The following is a description of a gene set: The change in morphology and behavior of a mast cell resulting from exposure to a cytokine, chemokine, soluble factor, or to (at least in mammals) an antigen which the mast cell has specifically bound via IgE bound to Fc-epsilonRI receptors, leading to the initiation or perpetuation of an immune response. Mouse Gene Set: GOBP_MAST_CELL_ACTIVATION_INVOLVED_IN_IMMUNE_RESPONSE species: Mus musculus, and this is the list of marker genes: Grp, Hmox1, Gata2, Ighe, Lyn, Nppc, Gata1, Adora3, Cbl, Chga, Il13, Milr1, Cd84, Fcer1a, Mrgprb1, Ms4a2, Ywhaz, Rab44, Syk, Enpp3, Mrgprx2, Fcer1g, Slc18a2, Ptgds, Fer, Fes, Scn11a, Pld2, Clnk, Sphk2, Nppa, Ptgdr, Unc13d, Il4, Snx4, Cplx2, Nr4a3, Gpr15lg, Adora2b (adenosine A2b receptor), Il4ra, Kit, D6Wsu163e, Stxbp1, Tac4, Lilrb4a (leukocyte immunoglobulin-like receptor, subfamily B, member 4A), Cd300a, Lat2, Vamp8, Foxf1 (NCBI Gene Id 15227), Crhr1, Rabgef1, Gab2, Stxbp2, Pdpk1, Rasgrp1, Ptpn6, Il13ra2, Rac2, Btk, Pla2g3, Snap23, Lat, Fgr (NCBI Gene Id 14191)